The following is a description of a gene set: Human Gene Set: GOCC_FICOLIN_1_RICH_GRANULE_MEMBRANE species: Homo sapiens The lipid bilayer surrounding a ficolin-1-rich granule., and this is the list of marker genes: ADGRE3, CLEC4D, PTPRN2, DIAPH1, STBD1, SLC11A1, RHOA, ENPP4, DSC1, SLC2A3, DYNC1LI1, SERPINB12, ATP6AP2, TCIRG1, NFASC, PKP1, CD300A, FCER1G, TMEM179B, AP2A2, FCAR, ARL8A, UBR4, ATAD3B, DSG1, SERPINB10, TBC1D10C, LAMP2, SIGLEC14, LAMTOR1, COPB1, DYNLL1, CD55, ADAM8, VPS35L (VPS35 endosomal protein sorting factor like), FPR1, CD93, CD58, NCKAP1L (NCK associated protein 1 like), CR1, RAC1, SIGLEC5 (sialic acid binding Ig like lectin 5), ITGAX, NBEAL2, SIRPA, DOK3, LILRB2, MGAM, ATP6V0A1, DSP, LAMP1, ATP6V0C, LGALS3, TRPM2, CLEC4C (C-type lectin domain family 4 member C), ITGB2, GAA, FPR2, PRCP, SERPINB6, LILRA3